Given this list of marker genes Abcd1, Abcd2, Abca12, Pex19, Abca7, Abca9, Abcg8, Abcg1, Abca6, Abca5, Abcg5, Apoa1, here is a description of the gene set: electronically inferred by orthology from the curated human pathway part of: ABC-family protein mediated transport Reactome Pathway: ABC transporters in lipid homeostasis studied in species Mus musculus This event has been computationally inferred from an event that has been demonstrated in another species.<p>The inference is based on the homology mapping from PANTHER. Briefly, reactions for which all involved PhysicalEntities (in input, output and catalyst) have a mapped orthologue/paralogue (for complexes at least 75% of components must have a mapping) are inferred to the other species.